Given this list of marker genes ABCA3, TP53I3 (NCBI Gene Id 9540), GSTO2, UNC5D, HS6ST2, SNX29, ANGPT1, OTUD7A, C12orf56, THSD7B, GRIP1, PPARGC1A, CDH3, LINC01503, ANKRD22, EYA4, LINC01644, LINC00173, ENSG00000257989, TBATA, MYO3A, CDH1, FOXN1, NRXN3, GLB1L3, B3GALT5, C1RL-AS1, SYNPO2, EPB41L4A, GABRG3, PLXDC1, LINC01250, SDK1, MIR31HG, LARGE2, IQSEC3, CCL25, CACNB4, HSPA4L, KREMEN2, SLCO2A1, CLEC1A, RNF43, PTPN3, CACNB2, PTPRF, ALOX12P2, EVA1A, FRMD1, DSG3, MTCL1, SORCS1, ENPP7P10, ARHGAP42, PAX9, TRPM6, RHPN2, CNTN3, FYB2, GLI2, PPP1R26-AS1, TOX3, RBMS3, RPS6KA6, ENSG00000235834, GHR, MAP7D2, GPHN, SH3RF3, SGSM1, PNMA8A, MGMT, NKAIN4, PAPLN, FAS, SORCS2, MOB3B, SYNE1, NEURL2, RMST, COL4A6, CDC14B, KLF3-AS1, EGFR, ANKRD18A (ankyrin repeat domain 18A), RARG, TP53AIP1, CDS1, GGA2, XKR4, PRKG1, CD274, AFAP1L2, BNC2, KRT5 (NCBI Gene Id 3852), KANK1, ERICH3, TRPM3, SGPP2, SLIT3, NPTX1, ANKFN1, PATJ, ROBO2, DANT2, DPH6-DT, CMYA5, RPS23P6, GPLD1, TENM3, CLIC6, ADGRG2, PPFIA3, BCL10-AS1, ADARB2, DSC2, CGNL1, SLC44A3-AS1, MAPK4 (mitogen-activated protein kinase 4), ZRANB2-DT, ATP10B (NCBI Gene Id 80225), IL1RAPL2, CLTCL1, EXOC3L4 (exocyst complex component 3 like 4), PRSS16, BCHE (NCBI Gene Id 590), KRT19, LMO3, COL17A1, NPHS1, MCF2L, FAT2, ADAMTS14, ZNRF3-IT1, FMN1, SYNDIG1, SLC36A1, TP63, OSMR-DT, C11orf16, ESRP1, IGDCC3 (NCBI Gene Id 9543), COL26A1, FAM163A, PTPN13, NHS, CLEC2L, KCNJ5, CSRNP3, ASTN2, EYA1, GSTCD-AS1, COL19A1 (collagen type XIX alpha 1 chain), SEZ6L, PTPRT, PNCK, DPP6, KCNQ3 (potassium voltage-gated channel subfamily Q member 3), EPHA6, PITRM1, CDH4, MICALL2, ANO9, HSPB8, ANK3, LINC00963, HSPA12A, CACNA1I, OXCT1, KIAA1549, MPZL2, LINC01500, CLVS1, SLC6A1, COL27A1, CAP2, PLEK2, ST7, BCAS4, SORBS2, CDH7, ENPEP, NPFFR2, IRF6, FAM83B, FAM135B, DEPTOR, PASK, MYO5B, RASEF, ENSG00000255367, ZNF483, MIR3936HG, SLC9A3-AS1 (SLC9A3 antisense RNA 1), FAM20A, FGFR2, FREM1, PKP1, PKNOX2, H2AZ1-DT, ESRRG, KCNH7, IL31RA, CTSV, MGAT4C, NPIPB2, TMEM63B, LINC01482, KCTD1, SLC46A2, SLC46A1, ADAMTS17, CYP26B1, ACTA2, ENSG00000228793, TLE2, PLTP, KCNIP3 (potassium voltage-gated channel interacting protein 3), MAPK10, ACHE, BMP7, L3MBTL4, UST, EYA2, CXXC4, ENPP6, SPOCK1, PLEKHH3, B3GAT2, EARS2, LINC02955, ENPP3, TMEM163, WNK2, MIR205HG, EML6, SH2D4A, FRAS1, LRRC4C, B4GALNT3, RMDN2-AS1, LINC00511, ACO1, here is a description of the gene set: The gene expression program underlying the specification of human cell types is of fundamental interest. The study authors generated human cell atlases of gene expression and chromatin accessibility in fetal tissues. For gene expression, the study authors applied three-level combinatorial indexing to >110 samples representing 15 organs, ultimately profiling ~4 million single cells. The study authors leveraged the literature and other atlases to identify and annotate hundreds of cell types and subtypes, both within and across tissues. Our analyses focused on organ-specific specializations of broadly distributed cell types (such as blood, endothelial, and epithelial), sites of fetal erythropoiesis (which notably included the adrenal gland), and integration with mouse developmental atlases (such as conserved specification of blood cells). These data represent a rich resource for the exploration of in vivo human gene expression in diverse tissues and cell types. studied in species Homo sapiens from publication Cao J, O'Day DR, Pliner HA, Kingsley PD, Deng M, Daza RM, Zager MA, Aldinger KA, Blecher-Gonen R, Zhang F, Spielmann M, Palis J, Doherty D, Steemers FJ, Glass IA, Trapnell C, Shendure J (PMID 33184181) Marker genes curated from the annotated cluster as represented in the Descartes Human Gene Expression During Development database. Human Gene Set: DESCARTES_FETAL_THYMUS_THYMIC_EPITHELIAL_CELLS